Given this list of marker genes TRBV7-9, CD274, HLA-DQB2, PTPN11, PTPN6, HLA-DQA2, HLA-DRA, TRBV12-3, HLA-DPA1, CD4, HLA-DRB5, HLA-DPB1, TRAV19, HLA-DRB3, TRAV8-4, CD3D, HLA-DRB1, HLA-DQA1, HLA-DRB4, PDCD1, CD247, TRAV29DV5, CD3E, LCK, CD3G, HLA-DQB1, CSK, PDCD1LG2, here is a description of the gene set: Human Gene Set: REACTOME_CO_INHIBITION_BY_PD_1 Co-inhibition by PD-1 studied in species Homo sapiens